The following is a description of a gene set: studied in species Homo sapiens Broad femoral neck Human Gene Set: HP_BROAD_FEMORAL_NECK An abnormally wide femoral neck (which is the process of bone, connecting the femoral head with the femoral shaft)., and this is the list of marker genes: SLC39A13, RAB33B, DYM, MATN3, COG1, PTH1R, CANT1, UFSP2 (NCBI Gene Id 55325), COL10A1, SLC26A2, COMP, FZD2, TMEM53 (NCBI Gene Id 79639), CCN6, ARCN1, RAB3GAP2, ACVR1